Given this list of marker genes Rgs16, Stx18, Rnf4, Gab2, Elac1, Htra4, Grhl2, Slc9a6, Lipg, Treml2, Map3k9, Phf8, Fbxo46, Cpeb2, Vps26a, Cables1, Nsl1, Qser1, Dpysl5, Usp40, Atxn7l3, Tufm, Tnfsf11, Ptpa, Map2k3 (mitogen-activated protein kinase kinase 3), Sp4, Rcn1, Fam131b, Plxna4, Ly6c1, Mrpl51, Ap5z1, Fam78b, Ncam1, Dgki, Gem, Cyth2, Nptx1, Mtmr4 (NCBI Gene Id 170749), Tmem235, Arih2, Acvr2a, Atg16l1, Mtfr1, Btbd8, Mtss2, Dchs1, Itsn1, Nox4, Mob1b, Gprc5b, Snph, Ranbp9, Minar1, Epha10, Rybp, Ccdc50, Akt3, Dock11, Klf3, Hspb8, Ddit4, Pacs2, Pde7b, Eif4ebp2, Dnajc27, Cebpa, Zfp458, Nectin1 (NCBI Gene Id 58236), Pgs1, Edem3, Oxtr, Mzt2, Ercc8, Nedd9, Il17rd, Cramp1, Stmn4, Adcy1, Slc30a8, Nipsnap3a (nipsnap homolog 3A), Ap1s1, Sec16a, Rab5if, Ip6k2, Ism2, Psmb1, Kctd5, Arrb1, Med14, Gal3st4, Prrx1, Cldn12, Scoc (short coiled-coil protein), Prob1, Mcmdc2, Lims1 (LIM and senescent cell antigen-like domains 1), Zfp84, Cuedc1, Dedd, Sytl4, Tab3, here is a description of the gene set: Genes predicted to be targets of miRBase v22 microRNA mmu_miR_337_3p in miRDB v6.0 with MirTarget v4 prediction scores > 80 (high confidence targets). from publication Chen Y, Wang X (PMID 31504780) species: Mus musculus Mouse Gene Set: MIR_337_3P